The following is a description of a gene set: The 'NPM1-mutated signature 1': genes down-regulated in pediatric AML (acute myeloid leukemia) samples with mutated NPM1 compared to all AML cases with the intact gene. studied in species Homo sapiens Human Gene Set: MULLIGHAN_NPM1_MUTATED_SIGNATURE_1_DN Somatic mutations in nucleophosmin (NPM1) occur in approximately 35% of adult acute myeloid leukemia (AML). To assess the frequency of NPM1 mutations in pediatric AML, we sequenced NPM1 in the diagnostic blasts from 93 pediatric AML patients. Six cases harbored NPM1 mutations, with each case lacking common cytogenetic abnormalities. To explore the phenotype of the AMLs with NPM1 mutations, gene expression profiles were obtained using Affymetrix U133A microarrays. NPM1 mutations were associated with increased expression of multiple homeobox genes including HOXA9, A10, B2, B6 and MEIS1. As dysregulated homeobox gene expression is also a feature of MLL-rearranged leukemia, the gene expression signatures of NPM1-mutated and MLL-rearranged leukemias were compared. Significant differences were identified between these leukemia subtypes including the expression of different HOX genes, with NPM1-mutated AML showing higher levels of expression of HOXB2, B3, B6 and D4. These results confirm recent reports of perturbed HOX expression in NPM1-mutated adult AML, and provide the first evidence that the NPM1-mutated signature is distinct from MLL-rearranged AML. These findings suggest that mutated NPM1 leads to dysregulated HOX expression via a different mechanism than MLL rearrangement. from publication Mullighan CG, Kennedy A, Zhou X, Radtke I, Phillips LA, Shurtleff SA, Downing JR (PMID 17597811), and this is the list of marker genes: ELOC, LDLR, LRRN2, GPR6, CD34, CD7, TRPM4, DUSP5, KCNQ1, FAM171A1, PLEKHO1, XPNPEP1, CS, PLEKHG3, CD200 (CD200 molecule), TTC21B, BTN2A2, RUNX1T1, LAX1, SVIL, RAB4A, LRP4 (LDL receptor related protein 4), FHL1, TMEM243, HOXC4, CAMKK2, PRKAR1AP1, PDX1, FXYD5, PDE4D, EMC1, GAD1, TNFRSF25, ACLY, RASSF1, PDE2A, ATP10A, PLCB4, ESYT1, LPAR6, MLNR, TMPRSS2, RARA, EPHX2, NHERF1, SERPINF1, UBE2L3, PSMA6, CAPN3, DENND3, RAB11A, PSG6, PMAIP1, PI4K2A, PPM1F (protein phosphatase, Mg2+/Mn2+ dependent 1F), HSPB1, SNRK, RRP9, POU6F1, SPTAN1, CLXN, HPCAL1, TCF7, RETN, EPHB2, ABCD1, DGKD, ARL4C, COPS5, HEG1 (heart development protein with EGF like domains 1), APRT, GJB3, TERF2, CARM1, ZNF135, QARS1, ATP9A (NCBI Gene Id 654090), CHST7, WHRN, MAP4K1, OAZ3, TUFM, MEF2A, RERE, GDI2, RNF130 (ring finger protein 130), GRHPR (glyoxylate and hydroxypyruvate reductase), EIF3F, PPP1R16B, PYGB, BCAT1, FLAD1, GNAQ, EHD1, SUN2, TPPP3, GPM6B, RETREG1, GPI, PCSK6, PRAME, ACSL4 (acyl-CoA synthetase long chain family member 4), EEF1D (NCBI Gene Id 87167), ADAR, EIF6, FCAR, EIF3D, LTBP4 (NCBI Gene Id 8425), SCRN1, MPHOSPH6, MOB1A, UXT, ST14, DSC1, INSL3 (insulin like 3), PHB2, NBL1, ARID3B, NFYC, LAMP5, SURF1, PES1, XRCC6, RPL28, FOXO3